The following is a description of a gene set: B cell receptor signaling species: Homo sapiens Human Gene Set: WP_B_CELL_RECEPTOR_SIGNALING, and this is the list of marker genes: PIK3R2, PLCG2, PDPK1, RAC1, HCLS1, ATF2 (activating transcription factor 2), MYC, AKT1, IKBKG, SYK, LCK, MEF2D, HRAS, VAV1 (vav guanine nucleotide exchange factor 1), GRB2, E2F3, BRAF, BLK, CDC42, PIK3R1 (NCBI Gene Id 5295), MAPK1, SOS1, MAP2K1, PIP5K1A, PTPN18, CRKL, CD22, CAMK2A, CREB1, MAPK8, NCK1, PTPRC, KLF11, LAT2, GTF2I, NFATC2, LYN, IKBKB, TEC, CD79A, PIK3AP1 (NCBI Gene Id 118788), ELK1, CD81, BCL10, IRF4, PRKCD, MALT1, PRKCB, MAPK14, PTPN6, MAP2K6, RPS6KA1, CRK, RAC2, CARD11 (NCBI Gene Id 84433), FOXO1, NFKB1, GAB1, VAV2, INPP5D, CHUK, CR2, JUN, PIP5K1C, NFATC3, RAF1, GAB2, MAP2K2, MAPK9, REL, PIP5K1B, MEF2C, SHC1, DAPP1, MAX, CD79B, CBL, MAP4K1, GSK3B, RASGRP3, PTPN11, NFKBIA, BLNK, GSK3A, MAP3K7, ETS1, BCL6, ILF2, FYN, RAPGEF1 (Rap guanine nucleotide exchange factor 1), MAPK4, PIK3CG, PLCG1, SH3BP2, RELA, BTK, CD19